Given this list of marker genes Gsr, Gstm1, Gsta1, Foxp3, Slc1a5 (NCBI Gene Id 269874), Ggt5, G6pd2, Slc1a2, Grxcr2, Gpx5, Abcc5, Slc7a11, G6pdx, Gsta3, Prdx1, Gsto1, Nrf1, Gpx7, Prdx3, Ncf1, Anpep, Gstt1, Pgd, S100a9, S100a8, Slc6a9, Gpx1, Gstm7, Ggct (NCBI Gene Id 68252), Ctla4, Cyba, Gsto2, Prdx2 (NCBI Gene Id 98489), Gpx2, Ptgs2, Ggt7, Slco1a1, Txnrd2, Cd44, Gsta4, Mgst1, Grxcr1, Abcc2, Gclm, Txn1, Mgst3, Gpx3, Slc6a5, Prdx6b, Keap1, Gpx4, Gpx8, Sod1, Ncf4, Gstm4, Gstm2, Nfe2l2, Ggt1, Ptgs1, Alox5, Sod3, Gstk1, Ncf2, Gstm3, Gstp2, Txnrd3, Idh1, Gpx6, Gls (glutaminase), Gstp1, Gclc, Prdx6, Gsta2, Gss (NCBI Gene Id 98903), Hpgds, Prdx4, Gstt2, Rac1, Slco2a1, Lap3, Ggt6, Gstm5, Gstt3, Oplah, Cbs, Prdx5, Cybb, Txnrd1, Idh2, Sod2, Gstm6, Mgst2, here is a description of the gene set: studied in species Mus musculus Mouse Gene Set: WP_OXIDATIVE_STRESS_AND_REDOX_PATHWAY Oxidative stress and redox pathway